Given this list of marker genes GHRL (ghrelin and obestatin prepropeptide), LEPROTL1, GDF15, HNF4A, SOCS2, MBD5, JAK2, LEPROT, here is a description of the gene set: Human Gene Set: GOBP_REGULATION_OF_GROWTH_HORMONE_RECEPTOR_SIGNALING_PATHWAY species: Homo sapiens Any process that modulates the rate, frequency or extent of the growth hormone receptor signaling pathway. The growth hormone receptor signaling pathway is the series of molecular signals generated as a consequence of growth hormone receptor binding to its physiological ligand.